Given this list of marker genes Cib1 (calcium and integrin binding 1), Fgfbp1, Sp1, Atp5f1b, Nrp1, Srpx2, Pdpk1, Jcad, Pdgfb, Map3k3, Prkca, Sirt1, Tgfbr3, Prl2c2, Cd40 (CD40 antigen), Plk2, P2rx4, Adam17, Amot, Nus1, Akt3, Ets1, Amotl1, Hspb1, Rhoj, Nos3, Fgfr1, Igf2, Foxc2, Tmsb4x, Prkd1, Angpt1, Atp5f1a, Map2k3, Hdac9, Anxa1, Plg, Plcg1 (NCBI Gene Id 99130), Vegfc, Vegfa, Pik3c2a, Kdr, Gata2, Abl1, Ptgs2, Alox12, Igf1, Hmox1, Gab1, Tgfb1, Nfe2l2, Fgf18, Fgf2, Col18a1, Hdac7, Akt1, Prkd2, Stat5a, Thbs1, Hif1a, Hmgb1, Angpt4, here is a description of the gene set: studied in species Mus musculus Any process that activates or increases the frequency, rate or extent of the migration of the endothelial cells of blood vessels. Mouse Gene Set: GOBP_POSITIVE_REGULATION_OF_BLOOD_VESSEL_ENDOTHELIAL_CELL_MIGRATION